The following is a description of a gene set: from publication Jeffrey KL, Brummer T, Rolph MS, Liu SM, Callejas NA, Grumont RJ, Gillieron C, Mackay F, Grey S, Camps M, Rommel C, Gerondakis SD, Mackay CR (PMID 16474395) Human Gene Set: GSE3982_BASOPHIL_VS_TH1_UP In the present study we used Affymetrix oligonucleotide microarrays to produce gene transcription profiles for the major leukocyte types in humans. This comprehensive dataset enabled us to not only establish which genes were expressed in each leukocyte type, but also which genes were expressed in each subset after activation. The used of a comprehensive dataset of gene profiles from all the major human leukocyte subsets enabled a novel and powerful means for identification of genes associated with single leukocyte subsets, or different immune paradigms. Genes up-regulated in comparison of basophils versus Th1 cells. species: Homo sapiens, and this is the list of marker genes: ZBTB18, YLPM1, SOX13, CCDC87, BPESC1, KDM6A, PRM1 (protamine 1), PRPF3 (NCBI Gene Id 9129, pre-mRNA processing factor 3), MEIS2, IFITM2, P2RY13, TRIP4, CTCF, SH3GLB1, DPY19L1, PBX3, LAPTM4A (NCBI Gene Id 9741), IK, TFAP2B, SCP2, ZNF106, RRAGA, VCL, MUC5AC, USP15, BEX4, S100A4, SYCP2, CD164, LYL1, MTARC1, BTBD7, KATNIP, RPS15A, MGAM, STAG2, TMEM59, LMAN2L, MAF (NCBI Gene Id 4094), ADGRF1, BCLAF1, BCL6, FRAT1, ARB2A, FAM30A, MAP2K4, DCAF8, BIN2, SDCBP, SRSF6 (serine and arginine rich splicing factor 6), TSNAXIP1, MTERF1, NUDT2, EMILIN2, CAPRIN2, PGLYRP1, VPS11, ILRUN (NCBI Gene Id 79138), BACE2, MAP1LC3B, CFAP45, HOXA9, MUC7, PRDM4, POLR2A, ICAM2, LPIN1, PRKCB, BAZ2B, ASB8, P2RY14, H3C11, BACH2, AP3S1, PRKACB, C11orf71, CLK1 (NCBI Gene Id 1195), ZNF266, MEGF9, SYF2, PLBD1, MXD1, PTGS1, TRANK1, DNASE1L1, SMURF1, ANKRD55, POLR1D, IQGAP2, LMBRD1, S100P, FGR, ATP10D, GALC, POGZ, H4C11, PAX1, BBS9, ARHGEF40, AKAP9 (NCBI Gene Id 10582), DUSP1, FAF2, KIF5A, LGALS8, SLC4A3, UBA3, RHOA, UBXN2B, FBXL5, DSG1, LSM14A, VWA8, HP, GRIA1, ATM, PRDM8, NACA, SERINC3, MFSD1, AGTPBP1, SERINC1, ZNF32, IQCH, SPEN, ARHGDIB, TSC22D1, HLA-DPB1, SARAF, IQSEC1, BRD8, PTPRC, GSTA1, HCP5, RERE, GSK3B, HBP1, TREX2, KIT, RTN3, MKRN1, UBE2E3, LAMTOR2, TRAM1, MSL3, SH2B3, PLEKHF2, PRMT2, CCAR2, HBZ, ARHGAP15, WIPF1 (NCBI Gene Id 7456), PLAGL1, KDM5A, NPIPA1, CR1, ZNF280B, ZCWPW1 (zinc finger CW-type and PWWP domain containing 1), PCTP, HCK, PPP2R5A, COLQ (NCBI Gene Id 8292), KANSL1L, NFE2, RAB4A (NCBI Gene Id 5867), RPS25, N4BP2L2, PMP22, GRIA2, MTM1, STAT5B, NCF1C, KLHL24, OSGIN2, CTDSP2, R3HDM2, NDRG1, PCSK5, USP25, SVIL, SWAP70, CD9, SORBS1, SLC2A4, EXOC1, DSE (dermatan sulfate epimerase), FAM13B, MARCHF7, RNF139, CLCA2, TLR4, NTM, DENND4C, KLF9, PCMTD2, WSCD2, MBP, MAN2B2, PDGFC, EIF4A2